The following is a description of a gene set: To determine the influence of the microenvironment on changes in gene expression, we did microarray analysis on three variant lines of a human pancreatic cancer (FG, L3.3, and L3.6pl) with different metastatic potentials. The variant lines were grown in tissue culture in the subcutis (ectopic) or pancreas (orthotopic) of nude mice. Compared with tissue culture, the number of genes of which the expression was affected by the microenvironment was up-regulated in tumors growing in the subcutis and pancreas. In addition, highly metastatic L3.6pl cells growing in the pancreas expressed significantly higher levels of genes than did the L3.3 or FG variant cells. Growth of the variant lines in the subcutis did not yield similar results, indicating that the orthotopic microenvironment significantly influences gene expression in pancreatic cancer cells. These data suggest that investigations of the functional consequence of gene expression require accounting for experimental growth conditions. Human Gene Set: NAKAMURA_METASTASIS_MODEL_DN studied in species Homo sapiens from publication Nakamura T, Fidler IJ, Coombes KR (PMID 17210693) Bottom genes down-regulated in subcutaneous tumors from highly metastatic pancreatic cancer cells., and this is the list of marker genes: SERPINB1, EOMES, PID1, SNCAIP, PLAT, FGFBP1, FAM83A (family with sequence similarity 83 member A), P3H2, EHBP1L1, PMP22, FABP5, PTPRZ1, CAST, MUC2, RRAGD, SEMA4B, SLCO4A1, C3, OSBP2, TGFB1I1, POLM, ENKD1, RUNX2, TFPI, PTHLH, WIPI2, ACER3, UGCG (UDP-glucose ceramide glucosyltransferase), GLI3, TTC8, PLEK2, ALDOC, LDLR, IRX3, RAC2, SFXN3, TMEM167B-DT, DDB2, CD44, AK4, AQP3 (aquaporin 3 (Gill blood group)), TMEM120A, NTSR1, CALCA (NCBI Gene Id 87044)